Given this list of marker genes H2AC4, CHMP7, BRD2, PLK1, SGF29, CENPA, H4C4, VCPIP1, TASOR, H4C1, H4C15, PPHLN1, RUVBL2, ESCO2, SPI1, SIRT6, MACROH2A2, H4C8, H4C12, JARID2, H4C6, CTCFL, LEF1, H4C16, TONSL, RAD21 (RAD21 cohesin complex component), EZH2, PARP1, H2BC11 (H2B clustered histone 11), H4C9, MMS22L, ZMYND8, LEMD2 (NCBI Gene Id 221496), H2AC8, MACROH2A1, MRNIP, H4C3, INTS8, PIAS4, LRWD1, VCP, H4C2, ESR1, H4C13, H4C14, MCM9, SETD2, WAPL (WAPL cohesin release factor), VRK1, NIPBL, RNF4, H4C11, INTS6, BRD3, H1-5, FAM47E, SPIN1, WBP2, H4C5, CDK9, MCM8, LNCPRESS1, APLF, here is a description of the gene set: studied in species Homo sapiens Human Gene Set: GOBP_PROTEIN_LOCALIZATION_TO_CHROMATIN Any process in which a protein is transported to, or maintained at, a part of a chromosome that is organized into chromatin.